Given this list of marker genes Acta2, Snai2, Lef1, Twist2, Hmga2, Cdh2, Ets1, here is a description of the gene set: Epithelial and mesenchymal markers down-regulated in MEF cells (embryonic fibroblasts) after knockout of PRKAR1A. studied in species Mus musculus Dysregulation of protein kinase A (PKA) activity, caused by loss of function mutations in PRKAR1A, is known to induce tumor formation in the inherited tumor syndrome Carney complex (CNC) and is also associated with sporadic tumors of the thyroid and adrenal. We have previously shown that Prkar1a(+/-) mice develop schwannomas reminiscent of those seen in CNC and that similar tumors are observed in tissue-specific knockouts (KO) of Prkar1a targeted to the neural crest. Within these tumors, we have previously described the presence of epithelial islands, although the nature of these structures was unclear. In this article, we report that these epithelial structures are derived from KO cells originating in the neural crest. Analysis of the mesenchymal marker vimentin revealed that this protein was markedly down-regulated not only from the epithelial islands, but also from the tumor as a whole, consistent with mesenchymal-to-epithelial transition (MET). In vitro, Prkar1a null primary mouse embryonic fibroblasts, which display constitutive PKA signaling, also showed evidence for MET, with a loss of vimentin and up-regulation of the epithelial marker E-cadherin. Reduction of vimentin protein occurred at the posttranslational level and was rescued by proteasomal inhibition. Finally, this down-regulation of vimentin was recapitulated in the adrenal nodules of CNC patients, confirming an unexpected and previously unrecognized role for PKA in MET. from publication Nadella KS, Jones GN, Trimboli A, Stratakis CA, Leone G, Kirschner LS (PMID 18413734) Mouse Gene Set: NADELLA_PRKAR1A_TARGETS_DN